The following is a description of a gene set: studied in species Homo sapiens Genes predicted to be targets of miRBase v22 microRNA hsa-miR-3616-5p in miRDB v6.0 with MirTarget v4 prediction scores > 80 (high confidence targets). from publication Chen Y, Wang X (PMID 31504780) Human Gene Set: MIR3616_5P, and this is the list of marker genes: CNOT7, KCNMB2, ASPH, IRX2, FMO3 (flavin containing dimethylaniline monoxygenase 3), SEPHS1, RAB23, GPRC5A, SLC25A26, TRDN, ZNF483, MTMR2, RBM12B, COBLL1, PYGO1, GRM5, CXCL9, PTS, RNF32, MLANA, CACNA2D2, BIN3, HLA-DPA1, MARCHF2, DTWD1, UNC5C, SPMIP6, PCDHB12, APBB2, NHLH2, RNF213, C21orf91, BTBD7, ADPRHL1, WNK3, XYLB, SLC4A5, LYRM4, SLC25A23, EBF3, RPA1, TAGAP, GABRR1, PAQR5, CLC, SLC23A1, GNB5, SOSTDC1, SLC2A12, BMPR1A, ZNF155, RINL, E2F3, TYW3, GPR171, BSDC1, NR4A2, OST4, MED13, MCM9, CYP7B1, TMEM217, EPHA3, CROT, SNTN, BCL11A, RPL36A, CCNL2, TRIB2, EGFR, SPTLC3, KDM5B, HCN1, CLK2, SPOPL, CPA4, PRSS35, DYNAP, ITGB8, KRT32, SATB2, SASH1, WDR72 (NCBI Gene Id 256764), SHCBP1, DKK3, THAP10, CCDC186 (coiled-coil domain containing 186), MMUT, YAF2